Given this list of marker genes ELAVL1, COL5A1, PCDHB13, MTSS2, TMEM14B, NSFL1C, DGKH, RHBDF2, TPCN1, LIG4, ITGAV, EGLN3 (egl-9 family hypoxia inducible factor 3), BRSK1, AKT2, here is a description of the gene set: Genes predicted to be targets of miRBase v22 microRNA hsa-miR-3678-5p in miRDB v6.0 with MirTarget v4 prediction scores > 80 (high confidence targets). studied in species Homo sapiens Human Gene Set: MIR3678_5P from publication Chen Y, Wang X (PMID 31504780)